The following is a description of a gene set: electronically inferred by orthology from the curated human pathway Reactome Pathway: Organic anion transport by SLCO transporters species: Mus musculus This event has been computationally inferred from an event that has been demonstrated in another species.<p>The inference is based on the homology mapping from PANTHER. Briefly, reactions for which all involved PhysicalEntities (in input, output and catalyst) have a mapped orthologue/paralogue (for complexes at least 75% of components must have a mapping) are inferred to the other species. part of: SLC-mediated transport of organic anions, and this is the list of marker genes: Slco1a4, Avp, Slco1c1, Slco4c1